Given this list of marker genes BACE1, EXOSC3, SCN2A, ST8SIA3, SLC23A2, SKI (SKI proto-oncogene), ADTRP, RASA3 (NCBI Gene Id 22821), DBT, SEC62, UACA, MED19, MICAL2, SDC3, PIGS (NCBI Gene Id 94005), OTOR, ALDH6A1, TMEM213, PLCG2, FEN1, WDR33, TMEM201, PLEKHO2, PSMD11, CLN5, FAM107B, CAPRIN1, NMT2 (N-myristoyltransferase 2), NUMBL, CNBP, GALNTL6, NID2, C22orf23, ANGPTL2, MKRN1, SLC12A4 (NCBI Gene Id 6560), NRK, CKM, MTCL2, ATF3, MS4A14, CORO2A, CHPF, TSPAN5, SOS1, QSER1, G6PC3, CDK6, ZNF543, DDX3X, GOLPH3L, SATB1, CNOT10, SLC6A2, MAPK8, STC1, JAM3, EPHA3, PNPO, DAAM2, PLCL2, SRRM4, PHACTR4, PAPPA (pappalysin 1), WARS2, ASCL2, CTTNBP2NL, MARCKSL1, PTPRJ, DGKK, SIAH1, GRAMD1B, PIK3R3, MMP24, DNALI1, PRPS2, CAMK1D, SPHK2, SLC35B4, CYP20A1, FOXN3, ARFIP2, DSTN, MAP3K1, DCAF10, here is a description of the gene set: Human Gene Set: MIR4435 studied in species Homo sapiens Genes predicted to be targets of miRBase v22 microRNA hsa-miR-4435 in miRDB v6.0 with MirTarget v4 prediction scores > 80 (high confidence targets). from publication Chen Y, Wang X (PMID 31504780)